Given this list of marker genes HGF, CD44, METTL22, RGS2, SMPDL3B, CYP27A1, RAMP2, CSF2RA, DDO, HROB, RAB3A, SEC14L2, SLC6A8, DDX49, FNDC8, EFNB2, RIOK3 (NCBI Gene Id 8780), ISCA1, KRT3, HOXA6, TUSC2, GAS7, ATP6V0B, GNA15, MATN2, ATG9A, PLEKHM1, SNORA70, QARS1, HSFX2, P3H4, CALY, NOL3, CHP1, WDR45, RABGEF1, PLAAT1, DEF8, ACSBG1, EIF3L, PIAS3, PABPC4, WIPI2, EVPL, MYL11, SNCA, RAB31, CCKAR, PRKAR2A, LRRC23, TEX11, MAPT, SEMA6B, LRRC41, DNAJB5, CMTM6, SORL1, MPP1, ABCC6, EIF4EBP2, ZSWIM8, BNIP3L, SLC25A3, ALCAM, CFAP45, ASPHD1, IGFBP6, SSX5, CABP1, NTRK1, LZTS1, RRAGD, MAP2K5, KCNJ12, NPHP4, SOD2, NRG1, YBX3, RTN3, DPY19L1P1, EIF3D, GRK1, METTL9, FOXC2, SEPTIN5, EXOG, RPL21P2, NENF, TPSAB1, CLIC1P1, SDC4, PTDSS2 (phosphatidylserine synthase 2), PLD2, KRT1, ALDH1B1, CALD1, CTNNBIP1, TUBGCP2, HAGH, MFAP4, STEAP3, KCNJ4, ZCCHC14, PCBP2, MPC1, TESC, FABP1, COX4I1, MICAL2, CHRNA4, KRT81, PINK1, EIF3F, OPLAH, FSCN1, CPD, HMGB3P30, POU4F3, ATRN, SPATA2L, GAS1, VENTX, ZDHHC7, IL17B, EIF1, PCTP, LMNA, PKP3, BTF3, GSTZ1, KCNQ4, TOLLIP, CELSR1, HOXA9, NXF1, PKNOX2, RNF10, DOCK6, MNT, CPNE6, EPAS1, ZDHHC3, BTF3P13, REPS2, VAMP3, SLCO3A1, CSNK1D, CYBRD1, TALDO1, ICAM5, MBOAT7, MARCHF8, BTBD7, AP1S1, EPB42, PRSS50, GNA12, FOXB1, ALPG, DUSP9, NSFL1C, SLC52A1, DELE1, PLA2G1B, TNFRSF10D, F7, OXCT2 (3-oxoacid CoA-transferase 2), HEYL, MAP2K3, ACHE, RPL7P52 (ribosomal protein L7 pseudogene 52), LINC00963, TMA7, SLC38A3, PITPNA, ETHE1, AOAH, here is a description of the gene set: Genes down-regulated in comparison of peripheral blood mononuclear cells (PBMC) from patients with acute influenza infection versus PBMC from patients with acute S. aureus infection. Each infectious agent represents a unique combination of pathogen-associated molecular patterns that interact with specific pattern-recognition receptors expressed on immune cells. Therefore, we surmised that the blood immune cells of individuals with different infections might bear discriminative transcriptional signatures. Gene expression profiles were obtained for 131 peripheral blood samples from pediatric patients with acute infections caused by influenza A virus, Gram-negative (Escherichia coli) or Gram-positive (Staphylococcus aureus and Streptococcus pneumoniae) bacteria. Thirty-five genes were identified that best discriminate patients with influenza A virus infection from patients with either E coli or S pneumoniae infection. These genes classified with 95% accuracy (35 of 37 samples) an independent set of patients with either influenza A, E coli, or S pneumoniae infection. A different signature discriminated patients with E coli versus S aureus infections with 85% accuracy (34 of 40). Furthermore, distinctive gene expression patterns were observed in patients presenting with respiratory infections of different etiologies. Thus, microarray analyses of patient peripheral blood leukocytes might assist in the differential diagnosis of infectious diseases. studied in species Homo sapiens from publication Ramilo O, Allman W, Chung W, Mejias A, Ardura M, Glaser C, Wittkowski KM, Piqueras B, Banchereau J, Palucka AK, Chaussabel D (PMID 17105821) Human Gene Set: GSE6269_HEALTHY_VS_STAPH_AUREUS_INF_PBMC_DN